Given this list of marker genes Ffar1, Plcb3, Hrc, Atp2a2, Gimap5, Cacng1, Mcoln1, Tgfb2, Trpc1, Tgfb1, Plcg1, Prkd1, Cemip, Htr2a, Npsr1, Cacng7, Trpv5, Pml, Cacna1i, Ptpn6, Cyba (NCBI Gene Id 13057), Ccl21a, Grin2a, Tlr9, Ednrb, Ryr3, Fbxo11, Cacnb2, Maip1, Cacng3, Chd7, Psen2, Flna, Hpca, Ahr, Adcyap1r1, Ccl19-ps5, Trpm8, Pkd1, Ccl19, Gas6, Stimate, Cacna2d3, Ccl3, Mcoln2 (NCBI Gene Id 99673), Prnp, Cd4, Calm2, Atp2c2, Itpr1, Sumo1, Dhrs7c, Ppp3r1, Ppp3ca, Cx3cl1, P2ry12, Bin1, Stac2, Itpr3, Cxcr3, Opa1, Xcr1 (NCBI Gene Id 23832), Abl1, Grin2b, Atp2b1, Akt1, Ptger3, Fgf2, Nipsnap2 (nipsnap homolog 2), Ccl21e, Drd4, Cav3, Orai1, Gstm7, Lck, Cav1, Mrln, Atp2a1, Tmc1, Ccl21d, Hap1, Cacna1g, Strit1, Calhm3, Orai3, Tmem38b, Grxcr1, Ccr5, Asic1, Hspa9, Il13 (interleukin 13), Adra1a, Jsrp1, Casq1, Catsper4, Grin3b (NCBI Gene Id 170483), Atp2b3, Dysf, Trpa1, Grin3a, P2rx1, Slc25a25 (NCBI Gene Id 68663), Rem1, Letm2, Htr2b, Epo, Trpc6, Ccl21b (NCBI Gene Id 20298), Tmco1, Plcg2, Nppa, Pkd1l1, Htr2c, Plp1, Stim1, Cacna2d1, Adrb2, Plcl2 (phospholipase C-like 2), Ntsr1, Ubr3, Atp2a3, Ccl19-ps6, F2, Slc24a3, Trpm3, Thy1, Oga, Gp9, Drd1, Ghitm, Fasl, Ero1a, Aplnr, Calm1, P2rx4, C2cd6, Ccl19-ps3, Cd19, Gimap3, Mcur1, Cacna1a, Gp1ba, P2rx6 (NCBI Gene Id 18440), Fyn, Slc24a4, Trpm2, Pdpk1, Sestd1, Bhlha15, Gper1, Htt, Gpm6a, Trpc5, Ms4a2, P2rx3, Nalf2, Drd2, Trpc3, Kcnj8, Tmem165, Fkbp1b, Ppp3r2, Itpr2, Sri, Spg7, Jph3, Gpr39, Cacna1e, Cacnb3, Trpv6, Capn3, Plcb1 (phospholipase C, beta 1), Slc35g1, Plcb2, Tspan13, Grin2c, Trpv1, Lyn, Mcu, Smdt1, Tmem37, Rgs9, Ptprc, Trpv3, Slc8a2, Panx3, Nalcn, Cracr2a, Tpcn2, Ano9, Slc25a23, Ano6, Bdkrb1, Mettl21c, Plcb4, Tpcn1, Casq2, Ubqln1, Hspa2, Ccl19-ps4, Nalf1, Atp1b1, Trpm6, G6pdx, Coro1a, Pik3cg, Itgav, Cacng2, Camk2d, Bax, Atp2b4, Tmem38a, P2rx5, Trpm1, Clec4b1, Cnga3, Trdn, Fgf14, Vdac1, Ppp3cc, Fmr1, Cacna1s, Cacng6, Ank2, Snca (synuclein, alpha), Plce1, Cnga1, Slc8b1, Calm3, Catsper1, Ppp3cb, Wnt3a, Ehd3, Asph, Cacna1h, Slc24a2, Adrb1, Bcl2, Trpc7, Cnga2, Ccl21f, Grin1, Akap6, Gp5, Slc8a3, Slc8a1, Trpc4, Prkce, Panx1, Trpm7, Cacna2d2, Jph2, Trpm4, Gpr35, Micu1 (mitochondrial calcium uptake 1), P2ry6, Sln, Ibtk, Cacna1f, Cacna1d, Vmp1, Atp2c1, Xcl1, Cacnb4, Cacng4, Cacng8, Cacna2d4, Dmd, P2rx7, Plch2, Gnb5, Ngf, Tmc2, Slc9a1, Ddit3, Catsper3 (cation channel, sperm associated 3), G6pd2, Cxcl11 (chemokine (C-X-C motif) ligand 11), Itgb3, Bak1, Lhcgr, Gsto1, Ccn2, Trpv2, Stim2, 1810037I17Rik, Micu3, Stac, Pawr, Cxcl9, Gp1bb, Cherp, Trpv4, Pln, Nol3, Plcl1, Trpc2, Fcrl5, Fkbp1a, Micu2, Slc24a1, Akap5, Cxcl10, Agtr1a, Letm1, Edn1, Cacna1b, Rapgef3, Ednra, Ahnak, Pkd2, Grm7, Catsper2, Smim6, Grin2d, Scn11a, Lime1, Atp13a4, Hrh1, Pkd1l3, F2rl3, Ryr1, Bmp4 (bone morphogenetic protein 4), Afg3l2, P2rx2, Ywhae, Myo5a, Glp1r, Calhm1, Diaph1, Tmbim6, Ubash3b, Ccl19-ps1, Ptpn22, Selenon, Psen1, Ptk2b, Pde4d, Atp2b2, Cacnb1, Cbarp, Pkd2l1, F2r, Gjc2, Atg5, Zfas1, Orai2, Atp1a2, Ryr2, Stac3, Slc24a5, Ucp2 (uncoupling protein 2 (mitochondrial, proton carrier), NCBI Gene Id 22228), Grm6, Plch1, Mcub, Ms4a1, Kcnn4, Cacna1c, Sec61a1, Ncs1, Dbi (NCBI Gene Id 13167), here is a description of the gene set: A process in which a calcium ion is transported from one side of a membrane to the other by means of some agent such as a transporter or pore. studied in species Mus musculus Mouse Gene Set: GOBP_CALCIUM_ION_TRANSMEMBRANE_TRANSPORT